The following is a description of a gene set: The directed movement of cholesterol, cholest-5-en-3-beta-ol, or cholesterol-containing compounds, by membrane-bounded vesicles. Human Gene Set: GOBP_VESICLE_MEDIATED_CHOLESTEROL_TRANSPORT studied in species Homo sapiens, and this is the list of marker genes: VPS52, PIP4K2A, VPS51, VPS54, CES1, TPCN2, ARL8B, VPS53, SYT7